Given this list of marker genes PRKAG2, IRX5, PKP2, JUP, TMEM43, GJA5, here is a description of the gene set: Increased time for the complex comprised of the Q wave, R wave, and S wave as measured by the electrocardiogram (EKG).. In adults, normal values are 0.06 - 0.10 sec. Prolonged QRS complex studied in species Homo sapiens Human Gene Set: HP_PROLONGED_QRS_COMPLEX